Given this list of marker genes Sstr1, Sstr5, Sstr2, Sstr4, Sstr3, here is a description of the gene set: species: Mus musculus Combining with somatostatin to initiate a change in cell activity. Somatostatin is a peptide hormone that regulates the endocrine system by signaling via G protein-coupled somatostatin receptors. Somatostatin has two active forms produced by proteolytic cleavage: a 14 amino acid peptide (SST-14) and a 28 amino acid peptide (SST-28). Mouse Gene Set: GOMF_SOMATOSTATIN_RECEPTOR_ACTIVITY